Given this list of marker genes ERF, SLC41A1, TWIST2, TRIM49C (tripartite motif containing 49C), AGTPBP1, IL31RA, RUNX3, MYO18A, PPP4R1, CREB3L1, BPIFC, DENND2B, PEPD, S100A7A, RAB5B, PCBD1, PHB2, ABLIM2, BLTP3A, CYB5RL, GFAP, AFAP1, GABPB1, PLEKHG4B, PRKRIP1, CELSR2, DCTN5, MINK1, UBE3B, ELMO2 (engulfment and cell motility 2), GABRA1, CHI3L2, RSPRY1, SYNJ1, SLC2A3, KLK4, QSER1, SEL1L, TRIM35, RPP14, C15orf39, TRAK1, DRG2, HYCC2, TOB2, NMNAT3, BICD2, ITGA5, SMC3, BDNF, KDM3B, TMEM266, STK4, SYNJ2BP, MED19 (mediator complex subunit 19), MTF1 (NCBI Gene Id 4520), AMN1, HIP1, ADAMDEC1, XKR4, CLDN9, KHDRBS1, MTCL2, ARRB1, FCRL4, RNF2, CASP9 (caspase 9), CLEC1A, NDEL1, AGAP1, CYTL1, PALM2AKAP2, MUSTN1, NIPAL3, CTSA, CASP2, IGFBP5, KCNA5, STIMATE-MUSTN1, THBS3, NRF1, LASP1, PTPN4, BTRC, ACOD1, TBC1D16, ATG7, DSN1 (DSN1 component of MIS12 kinetochore complex), RASA2, ZNF397, TP73, DTNB, HIPK1, CNOT3, EGFR, TANC1, SLC2A14, ATRN, FOXC1, PTPRJ, B3GNT7, SOX10, ADD2, KBTBD2, TGFBR1, GASK1B, BMF, TMEM253, CAMK1D, SLC23A2, LARP1, MTR, PSENEN, ZNF704, PLXDC2, PLEKHM3, SLC25A36, CD34, THOC7 (NCBI Gene Id 80145), LARGE1, PTPRT (protein tyrosine phosphatase receptor type T), DLGAP3, TRIM49, IL18BP, ADARB2, KIAA2013, TMEM95, KCNE3, PIK3C2A, SYNPO2L, ATXN7L3, BEND4, CNOT9, KSR2, ABCC1, OXSR1, SHISA7, DSG1, CBX5, BCL9, URGCP, HSD17B8, IPPK, GALNT11, TGFBR2, AIFM3, ANKRD54, PPP2R2C, NXF1, PPBP, PLXNA4, L1CAM, VAPB, CACNB1, PAPPA, TMIGD3, HS1BP3, CDC37L1, SCN2B, HOXA7, EXD2, SPRED1, EFNB1, here is a description of the gene set: from publication Chen Y, Wang X (PMID 31504780) studied in species Homo sapiens Human Gene Set: MIR1343_3P Genes predicted to be targets of miRBase v22 microRNA hsa-miR-1343-3p in miRDB v6.0 with MirTarget v4 prediction scores > 80 (high confidence targets).